Given this list of marker genes Tmem106a, Ifng, Xbp1, Nfx1, Jak2, Cdk5r1 (cyclin dependent kinase 5, regulatory subunit 1), Ciita, Sirt1, Marchf8, Slc11a1, Il33, Tlr4, Taf7, Spi1, Cd40lg, Il10, Il4, here is a description of the gene set: Mouse Gene Set: GOBP_MHC_CLASS_II_BIOSYNTHETIC_PROCESS studied in species Mus musculus The chemical reactions and pathways resulting in the formation of major histocompatibility protein class II.